The following is a description of a gene set: Human Gene Set: GOMF_IONOTROPIC_GLUTAMATE_RECEPTOR_BINDING Binding to an ionotropic glutamate receptor. Ionotropic glutamate receptors bind glutamate and exert an effect through the regulation of ion channels. studied in species Homo sapiens, and this is the list of marker genes: CDK5R1, SHISA7 (shisa family member 7), NETO2, CACNG8, DLG3, NSG1, CACNG4, DLG2, RAPSN, GRIPAP1, NEDD4, SRC, PTK2B, FLOT1, SHISA6, OPHN1, DRD2, DLG4, MT-ND2, NETO1, IGSF11, CACNG2, NSF, SHANK2, SQSTM1, CACNG3, DLG1, GNAS, SHANK1, SHANK3